Given this list of marker genes Cfc1, Smad7, Inhba, Nodal (NCBI Gene Id 21792), Smad6, Magi2, Cripto, Synj2bp, Smurf1, Fkbp1a, here is a description of the gene set: studied in species Mus musculus Binding to an activin receptor. Mouse Gene Set: GOMF_ACTIVIN_RECEPTOR_BINDING